Given this list of marker genes VPS54, CRLF1, BCL2, MAP3K12, ZPR1, MAP2K4, CNTFR, NEFL, ERBB3, ROCK1, RHOA, here is a description of the gene set: Any process that stops, prevents or reduces the frequency, rate or extent of motor neuron apoptotic process. Human Gene Set: GOBP_NEGATIVE_REGULATION_OF_MOTOR_NEURON_APOPTOTIC_PROCESS species: Homo sapiens